Given this list of marker genes EFNB1, CDK4, NDUFAB1, BMPR1A, CCNE1, MTHFD2, WEE1, STIL, NAF1, RGCC, BNIP5, MBOAT4, S1PR2, GMNN, AICDA, STXBP1, E2F3, RNASEH2B (ribonuclease H2 subunit B), C8A, PFN2, ENDOU, PGK1, HPF1, IGHG1, POLA1, HNRNPD, CENPL, SPC25, PTGR1, RAD51, U2AF1, CCNE2, ZP3, CFL1, CDC25C, EMB, STAU2, EAF2, POLE, RASGRF1, PITPNC1, TMEM126A, CPNE5, ERLIN1, KCNN4, GSC, NDUFC2, LPP, NCAPG, NDC1, CENPU, PCLAF, PPP6C, RTN4IP1, LOXL3, CHEK2, GAS2L3 (NCBI Gene Id 283431), HROB, TMEM256, ACAT2, TCF19, NCAPG2, LIG1, BUB1B, MRPS15, POGK, DDIAS, ALDH9A1, H2AZ1, SNRPA1, HEMGN, TMCO4, JAKMIP3, TROAP, ECT2, ESCO2, RFC3, KNSTRN, CD7, LHFPL4, NEIL1, RAD54L, C1orf122, PRIM1, VDAC3, PLK4, LMO7, SELENOH, CIP2A, DDX1, LSM5, KIF18B, PLPP1, NEXN (NCBI Gene Id 91624, nexilin F-actin binding protein), FANCD2, RGS10, KIF11, ARHGAP11A, ORC6, UBE2T, NEDD4, PCDHGC4, CCNA2, LPXN, CENPK, PA2G4, FABP5, MSI1, CMSS1, ASB4, S1PR3, TFB1M, NCAPH, CELSR1, SMAGP, TPI1, RFC4, ANLN, NT5M, ZWILCH, LEFTY1, ASNS, LPIN2, DMPK, EPPK1, TUBE1, TLCD2, SLCO4A1, ERI2, FAM135A, SKA1, SMIM6, DBF4, SPEF1 (sperm flagellar 1), DSCC1, USP6NL (USP6 N-terminal like), CPSF6, TOP1, CDC14B, LXN (NCBI Gene Id 56925), C6orf118, CASP3, GAL3ST1, KIF20A, PARPBP, NUP133, LCP2 (NCBI Gene Id 3937), MXD3, RFLNA, CENPV, ANKMY2, PPIL1, SLPI, CENPP, NANS, EIF4EBP2, SBF2, CDKN2C, PRR11, KIAA0930, DHFR, ARL5A, PHF10 (NCBI Gene Id 55274), PCED1A, CCDC18, TOX2, CRYBA4, ZNF365, FHL1, NEK2, UHRF1, ZNF473, GINS1, SRSF6, EXO1, TEDC1, CASZ1, ENY2, GNB4, C5orf22 (chromosome 5 open reading frame 22), OPTN, PTTG1, IFT27 (NCBI Gene Id 11020), ACKR2, ALG8, SLC12A2, UNG, PYCR2, MROH2A, HOXB7, ERCC6L, ANO3, GNG12, KIFAP3, TRIP13, PKP4 (plakophilin 4), IGF2BP3, CDCA2, RBBP4, BRMS1L, here is a description of the gene set: from publication Fu W, Ergun A, Lu T, Hill JA, Haxhinasto S, Fassett MS, Gazit R, Adoro S, Glimcher L, Chan S, Kastner P, Rossi D, Collins JJ, Mathis D, Benoist C (PMID 22961053) species: Homo sapiens Genes down-regulated in CD4 T conv over-expressing: FOXP3 versus IKZF4 and FOXP3. The transcription factor FoxP3 partakes dominantly in the specification and function of FoxP3+ CD4+ T regulatory cells (Tregs), but is neither strictly necessary nor sufficient to determine the characteristic Treg transcriptional signature. Computational network inference and experimental testing assessed the contribution of several other transcription factors (TFs). Enforced expression of Helios or Xbp1 elicited specific signatures, but Eos, Irf4, Satb1, Lef1 and Gata1 elicited exactly the same outcome, synergizing with FoxP3 to activate most of the Treg signature, including key TFs, and enhancing FoxP3 occupancy at its genomic targets. Conversely, the Treg signature was robust to inactivation of any single cofactor. A redundant genetic switch thus locks-in the Treg phenotype, a model which accounts for several aspects of Treg physiology, differentiation and stability. Human Gene Set: GSE40274_FOXP3_VS_FOXP3_AND_EOS_TRANSDUCED_ACTIVATED_CD4_TCELL_DN